Given this list of marker genes CTCFL, KCNN3, MCC, GALNT7, ARSJ, CPEB2, ONECUT2, SPAG9, ZNF586, HOOK1, ZNF398, MEF2C, DDIT4 (DNA damage inducible transcript 4), RAPGEF6, CPEB3, ANKRD50, OSBPL11, RPE, CALD1 (NCBI Gene Id 800), RPE65, FAXC, FBXO3, ZNF800, GPM6A, TNKS1BP1, MAB21L1, LGALS14, YTHDF3, BTG1, CDH2, CEP57L1, LIN28B, GGCT, CIPC, NUS1, PTX3, AKAP4, DENND5B, SLC41A2, ACSL4, LCOR, TMCC3, MOB1B, MSTN, FUT9 (NCBI Gene Id 10690), ARPC2, RUFY2, RYK, ITPR1, ADAMTS6, TMEM135, PGM3, DIAPH3, TCF12, ZNF470, ATP10A, LARP1, CEP83, CYP20A1, MB21D2, ZIC3, AFAP1L1, ADIPOR2, PIGG, SLITRK5, MFSD14A, SYDE2, NEFH, ZFAND5, KIAA1549L, CALU, RBM43, KLF12, TASL, DPP6, CCDC144A, SIGLEC14, ABCB5 (NCBI Gene Id 340273), ARHGEF26, RYR3 (ryanodine receptor 3), PHF20L1, SALL3, CFAP57, MYO5B, FPGT, ZMYM3, RPAP3, RGS7BP, PROKR2, FRAT1, PKNOX1, ARPP21, MAT2B, ITFG1, PAQR9, PDE7A, OTUD4, KLHL18, NRXN1 (neurexin 1), MUC5AC, TARDBP, ELF4, SCN2A, PRKAG1, DST, SDC2, QRICH1, ERO1B, TSPAN5, ZNF664, FAM117A, NLK, BBOF1, TANC2, ANKRD52, RWDD4, CXXC4, CAMSAP2, PPP2R3C, MFSD6, QKI, EPHX4, DDX3X, LINC00452, LIN54 (lin-54 DREAM MuvB core complex component), TMEM117, TNPO1, GPT2, ARB2A, ZBTB21, GSK3B, MTMR4, SMARCA5, UXS1, ZNF367, MAGI3, NOL4, APCDD1 (APC down-regulated 1), SLC6A6, CKAP4, TAF5, ATXN3, PDZD8, ZNF577, EEF2, here is a description of the gene set: Human Gene Set: MIR6513_3P studied in species Homo sapiens from publication Chen Y, Wang X (PMID 31504780) Genes predicted to be targets of miRBase v22 microRNA hsa-miR-6513-3p in miRDB v6.0 with MirTarget v4 prediction scores > 80 (high confidence targets).